Given this list of marker genes Fgf17, Fgf6, Fgf2, Fgf1, Fgf9, Gipc1, Fgf20 (NCBI Gene Id 80857), Fgf5, Tgfbr3, Fgf23, Fgf8, Fgfr1, Fgf4, here is a description of the gene set: studied in species Mus musculus Mouse Gene Set: REACTOME_FGFR1C_LIGAND_BINDING_AND_ACTIVATION FGFR1c ligand binding and activation